Given this list of marker genes ITPR1, ATOH7, RB1, TINF2, NDP, GNA11, ARL6IP6, FZD4, here is a description of the gene set: Human Gene Set: HP_LEUKOCORIA species: Homo sapiens Leukocoria An abnormal white reflection from the pupil rather than the usual black reflection.